The following is a description of a gene set: Hyperintensity of cerebral white matter on MRI Human Gene Set: HP_HYPERINTENSITY_OF_CEREBRAL_WHITE_MATTER_ON_MRI A brighter than expected signal on magnetic resonance imaging emanating from the cerebral white matter. studied in species Homo sapiens, and this is the list of marker genes: PUS3, INTS11, RARS1, PLP1, PDP1, NEUROG1, GFM2, MPV17, RPL10, PSAP, CLN8, DPYD, CSF1R, CNP, ZFYVE26, MSTO1, GNB2, NEUROD2, TM4SF20, CREBBP, B4GALNT1, NKX6-2, UBTF, COL4A1, CAMK2A, PYCR2, BRPF1, SPG11, ODC1, ABHD16A, ACTA2, GM2A, TMEM222, KCNH5, DDHD2, PRORP, CYP27A1 (NCBI Gene Id 1593), PAK1, MTOR, CACNA1G, ATN1, GAA, CYP7B1, CNBP, MMACHC, TBCK, HTRA1 (NCBI Gene Id 5654), RNU4-2, NOTCH3, LEMD2, STRADA (STE20 related adaptor alpha), TRPM3, AP5Z1, SELENOI, WARS1, SDHB, NSUN3, LMNB1, PIK3CA, CNKSR2, RAB3GAP2, AHCY, EP300, SPG21, ACTL6B, AKT3, SLC39A14, PI4KA, ALG2, SUOX, ABCC9, ARSA, RFT1, CTDP1, TREX1, SLC18A3 (solute carrier family 18 member A3), TRAPPC12